Given this list of marker genes Cep63, Cep152, Cdc20b, Ccdc78, Plk4, Deup1, here is a description of the gene set: Mouse Gene Set: GOBP_DE_NOVO_CENTRIOLE_ASSEMBLY Centriole assembly in which a centriole arises de novo, rather than by replication from an existing centriole. This process may occur via different mechanisms. Examples include the deuterosome pathway in multicilated epithelial animal cells and formation of centrioles during parthenogenesis in some insects. studied in species Mus musculus